The following is a description of a gene set: Human Gene Set: GOBP_CORTICAL_ACTIN_CYTOSKELETON_ORGANIZATION A process that is carried out at the cellular level which results in the assembly, arrangement of constituent parts, or disassembly of actin-based cytoskeletal structures in the cell cortex, i.e. just beneath the plasma membrane. species: Homo sapiens, and this is the list of marker genes: VIL1, EPB41, ROCK2, EZR, TLN1, IQGAP3, DLG1, FMNL1, RAB13, NCKAP1L, FMNL3, EPB41L1, ECT2, CALR, ROCK1, IQGAP1, AKAP11, ARF6, EHD2, PLEK, LLGL1, NCKAP1, RACGAP1, RTKN, STRIP1, IQGAP2, RHOQ, VPS4A, EPB41L2, KCNC3, ANLN, FHOD3, PDCD6IP (programmed cell death 6 interacting protein), PLS1, CAVIN3, LLGL2, PLEC (NCBI Gene Id 5339, plectin), FMNL2 (NCBI Gene Id 114793), LCP1 (NCBI Gene Id 3936), EPB41L3, FHOD1 (NCBI Gene Id 29109)